Given this list of marker genes PADI3, PADI6, PADI2, PADI4, PADI1, here is a description of the gene set: Human Gene Set: GOMF_PROTEIN_ARGININE_DEIMINASE_ACTIVITY studied in species Homo sapiens Catalysis of the reaction: H2O + L-arginyl- = L-citrullyl- + NH4+, resulting in citrullination of the target protein. This reaction is calcium-dependent.